Given this list of marker genes BICC1 (NCBI Gene Id 80114), PMS1, GNA14, KRIT1, GFI1, MAGT1, TPP2, ATP6V1B2, HAVCR2, CEP57, THSD1, CARMIL2, FH, TNFRSF10B, LMOD1, MAP2K1, VPS35L, NKX2-1, CHEK2, PDGFRL, MYD88, BLM, TJP2, GLI3, ECM1, REST, KCTD1, XPA, BDNF, PHKG2, ZSWIM6, TERC, GPC4, H19, RUNX1, ABCA5, BAP1 (BRCA1 associated deubiquitinase 1), MT-TF, SMAD4, COL7A1, FGFRL1, SOCS1, SOX2, SPI1, RYR1, SIX6, NTHL1, G6PC1 (NCBI Gene Id 2538), SLC12A3, ASL, MT-RNR1, RAD54L, TRPS1, ARHGAP26, DNAJB11, SRP72 (NCBI Gene Id 6731), IL6ST, IKBKG, DHCR24, COL4A6, BLK, MT-TP, MBTPS2, HLA-DQA1, ZNRF3, TNFSF15, GINS1, MC2R, RB1CC1, RPL35, TYR, MAP3K1, MYLK, CPLANE1, FLCN, RB1, PDE6D, ALX1, FOXC2, EXTL3, SMARCA4, TUBB, HSPA9, NOTCH3, ITK, MST1, SMARCAL1, TRAPPC14, FANCE, SLC25A13, TTC7A, STAT3, AHCY, CTC1, HDAC4, CTSA, TRPM3, H4C9, SLC45A2, BCL2, TYMS, ACVR1, TNFRSF13C, NOD2, RPGRIP1L, MAD2L2, RERE, SEMA4A, NDP, FANCL, OCA2, INTU, TGFBR1, ANGPT2, CAT, PSEN1, RPL10, FZD2, GPR161, KMT2D, GATA4, GATA2, PYGL, DDX41, SFTPA2, RIT1, ARID1A, LRRC8A, SOX6, SLC6A17, MFN2, FOCAD, NQO2, MRE11, KLF11, CREBBP, ATP7B, ACVRL1, RAD51C, ING1, KRT14, MCM4, KAT6B, NLRP1, MXI1, GPR101, PMS2, SUFU, MPL (NCBI Gene Id 4352), ALG9, DZIP1L, CYP2A6, MST1R, RMRP, RAF1, USB1, ELANE, HFE, IGF2R, TAL1, PDCD10, TET2, MRAS, PDGFB, ALX4, RAD50, ANTXR1, ROS1, AIP, IVNS1ABP (NCBI Gene Id 51489), PICALM, INS, ADH5, GCM2 (NCBI Gene Id 9247), RPL15, CTRC, ALAD, CDC73, DDX59, PTEN, USP48, SRP54, STK11, EIF3F, SEMA4D, CTHRC1, EYA1, SMARCE1, TREM2, MTMR14, RRAS2, CDKN1A, F13A1, HPGD, CASP8, CAPNS1, NFKB2, PRKAR1A, ACP5, RPS15A, NHP2, HABP2, EPHB4, COL14A1, MCC, KDM1A, POLR1C, XRCC2, TRIP13, ASCL1, FBXO28 (NCBI Gene Id 23219), CYLD, PARN, AXIN1, CD96, MMP23B, IGF2, IL6, ERCC2, LAMB3, SKI, PHF21A, PRLR, IKZF1, RPS20, CRKL, PHOX2B, HRAS, WAS, EFL1, KLHDC8B, TMC6 (transmembrane channel like 6, NCBI Gene Id 117165), SMPD1, MT-TS2, DPF2, NF2, GREM1, PKHD1, LPP, SHH, SAMD9L, DCC, GPR143, RAD51D, UROS, RAD21, CLCN2, NF1, FOXP1 (forkhead box P1), MITF, FGFR2, SDHB, CD27, RNASEH2A, RPS29, SLC25A11, C1S, KIF7 (kinesin family member 7), TMEM231, STAG3, TMEM106B, MT-TL1 (mitochondrially encoded tRNA-Leu (UUA/G) 1), RET, TOPORS, SRC, SKIC2, MTAP, TERT, SMARCB1, TP63, CHRNG, KIF1B, THPO, TRAF7, KRAS, SHOX, POGLUT1, ACAN, LMO1, TLR2, MBD4, RFWD3, RNASEH2B, SOX4, EIF2AK4, SMAD7, SAMD9, CD28, NSD1, LBX1, POFUT1, GTF2H5 (NCBI Gene Id 404672), CTBP1, ALG5, BMPR1A, XPC, ASCC1 (NCBI Gene Id 51008), PHKA2, PERP, STAR, ATP2A2, VPS16, RPS17, MSX2, ACVR1B, SH2D1A, FOXI1, RNF139, KCNH1, LEMD3, PPP2R1B, MEN1, MEG3, MPLKIP, DVL1, KCNN3, DLK1, MAFA, STAC3, CREB1, SPIB, VANGL1, RSPRY1, TNFRSF4, TMEM127, CDKN2C, CCDC22, BARD1, TRIM37, RARA, ABL1, SCN11A, GTF2E2, HLA-DQB1, FANCA (FA complementation group A), PLA2G2A, ANAPC1, MAD1L1, CYSLTR2, CASZ1, ERCC6, SERPINA1, STK4, XRCC4, TMEM216, STAT1, PRKACB, GNAS, GJA1, ESR1, TINF2, MN1, BCL10, CD19, RPL8, MRAP, JAK2, RPL11, TRPV3, PAX3, GBA1, CTLA4, TRIM28, DYNC2H1, MNX1, NSD2, TGFBR2, ADA, RAD54B, KDM6B, UBA1, SH2B3, POLR1B, RPS27, HAX1, KRT6B, FANCG, GDF5, HEPACAM, TAF15, SFTPC, MEFV, FIBP, MVD, EDN1, ELP1, SDHD, MYH8, USP9X, SPRED2, PDE11A, LRP1 (LDL receptor related protein 1), CC2D2A (coiled-coil and C2 domain containing 2A), STS, ENPP1, MAPT, WNT5A, AKT1, BCHE, SASH1, AAGAB, COL17A1, SLC2A2, TAF1, SLC26A2, NSUN2, IL2RG, TMC8, PIEZO1 (NCBI Gene Id 9780), DKC1, PIK3CA, EGFR, COL4A5, FAT4, IFIH1, CCL2, TGIF1, POLE, SDHC, INPP5E, DLL1, KDM6A (NCBI Gene Id 7403), NPM1, DHH, TWIST1, PALB2, ABCC6, DUT, ESCO2, UROD (uroporphyrinogen decarboxylase), GIMAP5, PCNA, STAT4, KCNJ11, SEC61A1, PRKN, RNU7-1, SNAI2, DDB2, NR5A1, NEUROD1, CHIC2 (NCBI Gene Id 26511), LAMC2, APC, RPS28, MUC5B, POLR1D, CHD6, FOXO1, NR3C1 (NCBI Gene Id 389335), PAX4, SPTBN1, LZTS1, PHB1, IL7R, TNFSF12, ZFX, CDK4, TERF2IP, ARMC5, TIAM1, CASR, GAS1, RBM8A, STIM1, MGAT2, RABL3, CRIPTO, WASHC5, ALX3, SRP19 (NCBI Gene Id 6728), AP2S1, SKIC3, SOX11, MLLT10, IDH1 (NCBI Gene Id 3417), TMEM107, BTK, MAP3K8, KIAA0753, KRT1, GPC3, ATP2B1, RASA1, TEK, CALR, ATR, PIEZO2, IPO8, PTH1R, KRT6A (NCBI Gene Id 93086), RNF31, BMPR1B, DLST, RNF43, OPCML, RASGRP1, ARSA, ATM, FGFR3, BCR, MT-TK, FCN3, DNA2, IFNG, BRAF, OFD1, EP300, FGF8, MGMT, CYP11B1, MPV17, TULP3, ARL6IP6, CD70, SHOC2 (SHOC2 leucine rich repeat scaffold protein), WRAP53, VHL, ADA2, TNPO3, SPRTN, KDSR, DOCK8, CIB1, CRELD1, EXT2, POLH, MYF6, FERMT1, SLC22A18, MAPK1 (NCBI Gene Id 5594, mitogen-activated protein kinase 1), WWOX, CR2, PDGFRB, ACD, BRIP1, TARS1, GCDH, HBB (hemoglobin subunit beta), NFIX, GJB3, CARD14, HNF4A, EVC, F5, BMP6, MINPP1, HSPG2, MT-TH, WIPF1, DDR2, MTOR, RNF113A, MYO1H, FANCB, FGF3, HS2ST1, LZTR1, RNF6, PDPN, CDH1, HSCB, PRDM10, SASH3, PPM1D, FOXH1, MYSM1, BUB3, BMPER, APC2, HLA-DRB1, TFE3, CSF3R, RECQL4, EPHB2, FOXE1, SPRED1, MUTYH, ZIC2, RAG2, DISP1, FLT3, COG1, CPLX1, IGHG2, FDPS, RPS10, CEL (NCBI Gene Id 1056), TG, ZEB2, SCN4A, RNU4-2, MDM2, GJB6, NAB2, FGFR1, PAX7, GDNF (glial cell derived neurotrophic factor), CCBE1, CLCNKB, SIX3, ASXL1, NOP10, EDN3, MYC, NUTM1, LIN28B, TSC1, LRBA, RTL1, GPR35, NFKB1, FAS, GCGR, FANCD2, MAN2C1, EPAS1, PALLD, STAT6, CYP11B2, SPEN, KLLN, TCIRG1, ABCB4, SCN10A, EXT1, MALT1, PIK3CD, KANSL1, GPC6, SIX1, LIG4, NELFA, LAMA3, ZFPM2, KCNQ1, GJC2, SEC23A, RHOH, CPOX, DNAJC21, GNB1, BMP2, RPL9, ERBB3, TREX1, PIGG, KIT, UBE2T, GLI2, PTCH1 (NCBI Gene Id 8015), KRT17, PPOX, ATP7A, COL1A1, TCTN3, FLT4, FAM20C, PTPN11, DNM2, NFATC2, NR0B1, ACTB, CEP120, PTPN6, FAH, COQ6, SLCO2A1, JAG1, MDH2 (malate dehydrogenase 2), DPM1, SLC39A7, MMP1, POR, SMO, CTNNB1, RASA2, SDHA, TYROBP, CTSC, TNFRSF13B, ABCC8, SMARCD2, BRCA1, XIAP, IL7, DLEC1, SBDS, MVK, RPL26 (ribosomal protein L26), BRD4 (bromodomain containing 4, NCBI Gene Id 90616), XRCC3, TCOF1, VAMP7, BPTF, DEF6, PLAG1, PPP1CB, CDH23, HNF1A, APPL1, EPCAM, RPS19, ALK, DIAPH1, TCF4, RPL35A, TNFRSF1B, KRT16, AGGF1, AARS1, SRD5A3, TSC2, SCARB2, CASP10, POU2AF1, SMARCD1, USP8, RAG1, SH3GL1, VANGL2, PUF60, OCRL, PRKCZ, WRN, CDON, KIAA0586, HNF1B, POT1, BIRC3, IRF5, ENG, PRF1, PDCD1, PNP, GABRD, FANCC, SOX9, LSM11, SLC26A4, ELMO2, PBRM1, PIK3R1, KLF6, ERCC4, MMEL1, RPA1, ICOSLG, NAGS, IFT140, DPYSL5, SRSF2, SOS2, FAM149B1, CEBPA, AP3D1, SQSTM1, FUZ, CDKN2A (NCBI Gene Id 1029), ETV6, POLD1, NBEAL2, L2HGDH, BUB1, PLCD1, DVL3, PDGFRA, SLC37A4, HACE1, POU6F2, GATA1, FANCI, GNA11, CXCR4, PLCB4, IL1RN, RNASEH2C, MT-TQ, DLC1, CD79B (CD79b molecule), CBL, SOS1, GCK, CD79A, ACTG2, PTPN3, AR, KCNAB2, TBX2, KDR, RTEL1, TFAP2A, PRKCD, F13B, PDX1, EVC2, PIGL, RPS24, PRKACA, TBC1D24, MYH11, SAMHD1, TCF3, GANAB, GRN, RPS7, CD4, TSR2, AXIN2, B3GALT6, MDM4, GDF2, IGHM, TBXT, ADAR, HMBS, NDUFAF6, RHBDF2, SF3B1 (splicing factor 3b subunit 1), TP53, PHKB, MET, NNT, AURKA, RNASEL, RRAS, GLI1, DYNC2LI1, PTPRC, GNAQ, SPINK1, LMNA, ABCB11, TMEM67, ASPSCR1, DIS3L2 (DIS3 like 3'-5' exoribonuclease 2), BUB1B, YY1, NBN, CDKN1C, WT1, PTPRJ, IGKC, MS4A1, MC1R, RPS14, CHD7, MLH1, FCHO1, MSL3, WNT10A, CLPB, BIN1, CDKN1B, ANTXR2, CACNA1S, MAPRE2, KARS1, SRGAP1 (SLIT-ROBO Rho GTPase activating protein 1), CDKN2B, CYP26C1, SOX5, MAP2K2, FLNA, FANCM, LUZP1, FANCF, FASLG, MSH3, SMARCC2 (SWI/SNF related, matrix associated, actin dependent regulator of chromatin subfamily c member 2), IKZF3, CHMP2B, MSTO1, SCN9A, GNPTAB, IL1B, OGG1, NAF1, KIF11, IL12A, MSR1, ADAMTS3, GNAI3, NOTCH1, FLI1, HEATR3, RPS26, SLX4, WDPCP, PTCH2, ERBB2, MYCN, DCLRE1C, NEK1, GJB2, LETM1, TAL2, PAX6, IGLL1 (NCBI Gene Id 8222), EWSR1, PKD1 (NCBI Gene Id 5310), RPL27, KRT5, GJB4, IL12RB1, SYK, BLNK, SETBP1, DNASE1L3, MAX, H4C5, SLC17A9, PRCC, PORCN, DNMT3A, RPL5, IDH2, MSH6, COL2A1, PTPN12, IRF2BP2, KRT10, FAM20A, C2CD3, NR4A3, DHX37, BCL6, BRCA2, PKD2, CD81, NUP214, NRAS, USF3, HOXD13, COL11A2, RPL31, ARID1B, HMMR, ICOS, RAD51, RPL18, ERCC5, RSPO1, ATRX, KEAP1, SEC23B, BAX, MT-ND5, TNFRSF9, NEK9, KCNJ10, CARS1, DICER1, SMARCAD1, CYP2D6, SRY (NCBI Gene Id 6995), CCND1, IRF1, PGM3, TXNRD2, VCP, ZFTA, CCM2, MSH2, PSENEN, UBE4B, DHCR7, PSAP, KCNE3, SDHAF2, CTPS1, KCNQ1OT1, MLH3, NODAL, ZFHX3, PRDM16, ZAP70, ERCC3, ARID2, here is a description of the gene set: Neoplasm studied in species Homo sapiens An organ or organ-system abnormality that consists of uncontrolled autonomous cell-proliferation which can occur in any part of the body as a benign or malignant neoplasm (tumor). Human Gene Set: HP_NEOPLASM